Given this list of marker genes LHX2, MAGEA3, MBD1, ETV1, KIR2DS4, MET, here is a description of the gene set: from publication Choi YL, Tsukasaki K, O'Neill MC, Yamada Y, Onimaru Y, Matsumoto K, Ohashi J, Yamashita Y, Tsutsumi S, Kaneda R, Takada S, Aburatani H, Kamihira S, Nakamura T, Tomonaga M, Mano H (PMID 16909099) Adult T-cell leukemia (ATL) is an intractable malignancy of CD4+ T cells that is etiologically associated with infection by human T-cell leukemia virus-type I. Most individuals in the chronic stage of ATL eventually undergo progression to a highly aggressive acute stage. To clarify the mechanism responsible for this stage progression, we isolated CD4+ cells from individuals in the chronic (n=19) or acute (n=22) stages of ATL and subjected them to profiling of gene expression with DNA microarrays containing >44,000 probe sets. Changes in chromosome copy number were also examined for 24 cell specimens with the use of microarrays harboring approximately 50,000 probe sets. Stage-dependent changes in gene expression profile and chromosome copy number were apparent. Furthermore, expression of the gene for MET, a receptor tyrosine kinase for hepatocyte growth factor (HGF), was shown to be specific to the acute stage of ATL, and the plasma concentration of HGF was increased in individuals in either the acute or chronic stage. HGF induced proliferation of a MET-positive ATL cell line, and this effect was blocked by antibodies to HGF. The HGF-MET signaling pathway is thus a potential therapeutic target for ATL. Human Gene Set: CHOI_ATL_ACUTE_STAGE species: Homo sapiens Acute stage-specific genes for adult T cell leukemia (ATL).